The following is a description of a gene set: Human Gene Set: GOBP_POSITIVE_REGULATION_OF_SMOOTH_MUSCLE_CELL_MIGRATION studied in species Homo sapiens Any process that activates, maintains or increases the frequency, rate or extent of smooth muscle cell migration., and this is the list of marker genes: MIR146A (microRNA 146a), MIR143, S100A11, XBP1, FAT1, CRK (CRK proto-oncogene, adaptor protein), VTN, ADAMTS1, NRP1, MIR448, HAS2, MIR21, TLR4, PAK1, DOCK5, MIR26A1, DOCK7, NR4A3, ITGB3, DOCK4, PDGFB, MIR221, MIR451A, SEMA6D, MIR135B, LPAR1, MIR499A, POSTN, MIR302C, PDGFD, FOXO4, ITGA2, AIF1, MIR20A, MDK, CCN4, SSH1, CCL5, PDGFRB, BCL2, DDR2 (discoidin domain receptor tyrosine kinase 2), MAP3K7 (NCBI Gene Id 6885), IGF1, MDM2, TERT, IGFBP5, FGF9